The following is a description of a gene set: from publication Baram D, Dekel O, Mekori YA, Sagi-Eisenberg R (PMID 20190146) Genes down-regulated in HMC-1 (mast leukemia) cells: untreated versus incubated with the peptide ALL1 followed by treatment with Cl-IB-MECA. studied in species Homo sapiens We demonstrate that the G protein Gi3 is the cellular target of the adenosine A3 receptor (A3R). By using a cell permeable peptide comprising the C-terminal end of Gαi3 fused to an importation sequence (ALL1) as a selective inhibitor of Gi3 signaling, we show that by coupling to Gi3, the A3R stimulates multiple signaling pathways in human mast cells, leading to upregulation of cytokines, chemokines and growth factors.Following contact with activated T cell membranes, endogenous adenosine binds to and activates the A3R, resulting in Gi3-mediated signaling. Specifically, the majority of ERK1/2 signaling initiated by contact with activated T cell membranes, is mediated by Gi3, giving rise to ALL1-inhibitable cellular responses. These results unveil the physiological GPCR that couples to Gi3 and establish the important role played by this G-protein in inflammatory conditions that involve adenosine-activated mast cells. We used microarrays to detail the effect of ALL1 on gene expression of HMC-1 cells activated directly by the A3 receptor, or by contact with activated T cell membranes. Human Gene Set: GSE19888_CTRL_VS_A3R_ACT_TREATED_MAST_CELL_PRETREATED_WITH_A3R_INH_DN, and this is the list of marker genes: CREBL2, SLC28A2, TRAK2, FAM114A1, STS, TLR4, CCR1, NEO1, RGMB, XPO6, HLX, CYFIP2, SVIP, RMND5B, IGFLR1, GNA15, CCL24, OSTM1, CTSE, MON1A, TRRAP, IL21, C19orf47, ANLN, TTI1, PRICKLE1, TYMS, STN1, LGR5, CCDC14, NFYC, HAPSTR1, OXNAD1, NSMAF, KNTC1, ZNF471, NONO, GABRG3, PRKAB1, PNRC1, GSE1, FBXW8, OXCT1, GPR35, DRG1, NDUFA9, IDUA, CCNE1, C2CD2, STX8, EHBP1 (EH domain binding protein 1, NCBI Gene Id 23301), ENOX2, C8B, MLYCD, PDSS2, CDIN1, SSBP4, CNST, WRAP53, TWIST2, ARID3B, RRAS, CLK2, GAPDH (glyceraldehyde-3-phosphate dehydrogenase), SAMD14, MON1B, WWOX, TNNI2, PIP5K1C, SORBS3 (sorbin and SH3 domain containing 3), PLEKHA5, NUMA1, LXN, ATP2A3, SHPK, FAM174C, POU2AF2, IGFBP6, NMRAL1, TUBE1, ABCB4, MT1E, EXOC7, CTRL, PAXX, TMEM241, NDUFV2, HCST, SAAL1, LAPTM5, CMTM6, IFT172, PKD2L2, INTS6L, DLG3, SYNJ2, CDK10 (cyclin dependent kinase 10), MZT2B, ZNF512B, UBE2V1, AGTPBP1, COMMD5, LENG9, RNASEL, FNDC8, DKK3, ANKRD39, FAAH, CTBS, MGST3, SLC35B4, GRINA, RDH5, ZBTB7B, ANGPTL2, CD163, GALNS, SCP2 (NCBI Gene Id 6342), CNN1, SCFD2, MARCO, SLC34A3, PABIR2, FBXO31, HOXB7, ZBTB45, RUFY1 (RUN and FYVE domain containing 1), PDXP (pyridoxal phosphatase), CPEB1-AS1, RILPL1, SPPL2A, SMCO2, BRD9, ZBTB9, B4GALNT2 (beta-1,4-N-acetyl-galactosaminyltransferase 2 (SID blood group)), RSRC1, MYBPC1, AIP, PRPF6, TMEM132E, GTPBP3, FERRY3, TSC22D4, AGBL4, NRDE2, KIF3C, HEPACAM2, ALKBH4, DAG1, NDUFAF7, SMURF2, RNASE4, SLC6A14, HIBCH, CFLAR, MED13L, CLASP1 (cytoplasmic linker associated protein 1), MFAP2, B3GNTL1, ADAMTS10, DDHD1, RIC8A, CERS6, PARP16, DIRAS1, HTRA2, ARSB, CHIC1, ATG4C (autophagy related 4C cysteine peptidase), MFSD3, GDF2, KLRK1 (NCBI Gene Id 22914), MAP3K1, CCR5, CAPN12, SLC22A17, PAPSS1, WWP2, ITGB5, PLCE1, ZCCHC24, OSGEP, SOD1, AQP6, TMEM273, TUBG1, NKTR, NUDT2, SEC22C, MUTYH, RPLP2, ZAN, ICMT, CD180, MFAP5, NAA10, SMPD5, ATP10A, PRR22